Given this list of marker genes AIRE, MMEL1, WAC, ARPC5, BBS12, SATB2, CEP19 (centrosomal protein 19), MST1, MKKS, STAT5B, MED12, BBS2, IL12RB1, BBS4, NPHP1, TNPO3, HLA-DQB1, IVNS1ABP, IFT27, IFT172, ODC1 (ornithine decarboxylase 1), SPIB, CEP290, MKS1, TBK1, IGKC, IFT74, SCLT1, IL12A, IRF5, IPO8, TNFSF15, ELN, SEMA4D, MLXIPL, TCF4, BICRA, BBIP1, SDCCAG8, BBS7, BBS10, TRIM32, GPR35, HLA-DQA1, TTC8, BBS9, IGHG2, LZTFL1, WDPCP (WD repeat containing planar cell polarity effector), POU2AF1, ARL6, SCAPER, BBS1, TBC1D7, SOCS1, BBS5, CFAP418, STAT3, SRCAP, here is a description of the gene set: studied in species Homo sapiens Human Gene Set: HP_CELIAC_DISEASE Celiac disease Celiac disease (CD) is an autoimmune condition affecting the small intestine, triggered by the ingestion of gluten, the protein fraction of wheat, barley, and rye. Clinical manifestations of CD are highly variable and include both gastrointestinal and non-gastrointestinal features. The hallmark of CD is an immune-mediated enteropathy. This term is included because the occurrence of CD is seen as a feature of a number of other diseases.